The following is a description of a gene set: The process in which the anatomical structures of branches are generated and organized. A branch is a division or offshoot from a main stem. Examples in animals would include blood vessels, nerves, lymphatics and other endothelial or epithelial tubes. Human Gene Set: GOBP_MORPHOGENESIS_OF_A_BRANCHING_STRUCTURE studied in species Homo sapiens, and this is the list of marker genes: ENG, SIRT6, BCL2, HOXA5, YAP1, BCL11A, FGF2, TBX3, GRHL2, TCF21, RSPO3, LAMA1, BMP2, DCHS1, NKX2-1, WNT4, VANGL2, KDR, DAG1, ERMN, BMP7, FOXD1, TFAP2C, PBX1, DDR1, SPRY2, SMO, HOXD13, LRRK2, FGF8, VEGFA, LEF1, PKD1, SPRY1, CITED1, GRB2, TIMELESS, CSMD1, FGFR1, PHB2, PKD2, NFATC4, TIE1, GLI2, FGF7, SHH, MDK, TNC, TGFBR2, PROX1, SEMA3E, FIGNL2, STK4, NRARP (NOTCH regulated ankyrin repeat protein), HMGA2, WNT5A (Wnt family member 5A), MAP3K13, ADAMTS16, ABL1 (NCBI Gene Id 25), PGR, SHOX2, HOXB13, RSPO2, SOX8, GPC3, MYCN, PLXND1, GBX2, WT1, COL4A1, FGFR2, HHIP, EXT1, SEMA3C, BMP4, NKX3-1, ETV5, PPP3R1, SLIT2, BTRC, FRS2, ACVR1, RTN4, HOXD11, ST14, SOX10, PML, KRAS, SPINT2, LAMA5, HS3ST3B1, HOXA11 (NCBI Gene Id 3207), IGF1, MET, LGR4, AR, ADM, GREB1L, DLL4, GZF1, DLG5, CTSH, EDNRA, CTNNB1, SIX1, TGM2, PDGFA, PAX8, SIX2, EYA1, DLG1, CCL11, EGF, PTCH1, GLI3, PITX2, FOXC2, FKBPL, PKHD1, MIR16-1, CASR, GDF7, TP63, TNF, AGTR2, FZD5, NRP1 (NCBI Gene Id 8829), SOX9, HNF1B, GDNF, CLIC4, SNAI2, NTN4, ILK, IHH, MMP14, CRIPTO, FEM1B, IL10, TACSTD2, HS3ST3A1, PPP1CA, SULF1, LHX1, GDF2 (NCBI Gene Id 51423), EDN1 (endothelin 1), CAV3, EPHA7, SMAD4, BTBD7, WNT6, SRC, PAK1, CTNNBIP1, EPHA2, SFRP2, NOG, RBM15 (NCBI Gene Id 64783), NPNT, FGF10, WNT2, ESRP2, SIX4, CSF1, GNA13, LRP5, NOTCH1 (NCBI Gene Id 54781, notch receptor 1), SOCS3, WNT2B, MSX2, RERE, SFRP1, RDH10, AGT, FOXA1, HGF (hepatocyte growth factor), AREG, TBX2, COL13A1, PAX2, CELSR1, SPINT1, PLXNA1, RASIP1, VDR, TGFB1, DRD2, HOXB7, TMEM59L, SALL1, GREM1, TBX20, MED1, MAGED1, CTNND1, WNT1, MKS1, FOXF1, MIR15B, CTSZ, DLX2, PRDM1, NOTCH4, SRF, FGF1, FGF13, LLGL2 (NCBI Gene Id 3993), GCM1, KDM5B, HOXA13, MYC, TMED2, ESR1, WNT9B